Given this list of marker genes Sox9 (NCBI Gene Id 70015), Bmp10, Smad4, Pim1, Rbpj, here is a description of the gene set: species: Mus musculus Mouse Gene Set: GOBP_POSITIVE_REGULATION_OF_CELL_PROLIFERATION_INVOLVED_IN_HEART_MORPHOGENESIS Any process that activates or increases the frequency, rate or extent of cell proliferation involved in heart morphogenesis.